The following is a description of a gene set: species: Mus musculus Directly binding to and delivering iron ions to a target protein. Mouse Gene Set: GOMF_IRON_CHAPERONE_ACTIVITY, and this is the list of marker genes: Pcbp2, Pcbp1, Dph3 (NCBI Gene Id 75408), Trf, Fxn